The following is a description of a gene set: EWS/FLI-1 is a chimeric oncogene generated by chromosomal translocation in Ewing tumors, a family of poorly differentiated pediatric tumors arising predominantly in bone but also in soft tissue. The fusion gene combines sequences encoding a strong transactivating domain from the EWS protein with the DNA binding domain of FLI-1, an ETS transcription factor. A related fusion, TLS/ERG, has been found in myeloid leukemia. To determine EWS/FLI-1 function in vivo, we engineered mice with Cre-inducible expression of EWS/FLI-1 from the ubiquitous Rosa26 locus. When crossed with Mx1-cre mice, Cre-mediated activation of EWS/FLI-1 resulted in the rapid development of myeloid/erythroid leukemia characterized by expansion of primitive mononuclear cells causing hepatomegaly, splenomegaly, severe anemia, and death. The disease could be transplanted serially into naïve recipients. Gene expression profiles of primary and transplanted animals were highly similar, suggesting that activation of EWS/FLI-1 was the primary event leading to disease in this model. The Cre-inducible EWS/FLI-1 mouse provides a novel model system to study the contribution of this oncogene to malignant disease in vivo. studied in species Mus musculus from publication Torchia EC, Boyd K, Rehg JE, Qu C, Baker SJ (PMID 17875932) Mouse Gene Set: TORCHIA_TARGETS_OF_EWSR1_FLI1_FUSION_TOP20_DN Top 20 down-regulated genes in leukemic progenitor cells expressing activated fusion of ESWR1 and FLI1 compared to normal hematopoetic progenitors., and this is the list of marker genes: Gsta4, Hoxa9, Grb10, Cnn3, Prkd3, Galnt7 (NCBI Gene Id 26911), Cd81, Sox4, Dock10, Ptgr1, Tmsb10, Slc6a13, Lgals1, Phgdh, Ppbp, Tgm2, Cdc42ep3, Smo, Arhgap15